Given this list of marker genes Tln1, Ndufb8, Rrp1 (NCBI Gene Id 18114), Tecr, Rgs3, Tmed10, Scgb1a1, Tmem160, Cdkn2c, Mt1, S100a8, Calm1 (calmodulin 1), Hspb1, Sf3b2, Gstp1, Tmt1a, Psme1, B2m, Ftl1, Trappc1, Ybx1, Cd63, Npdc1, Phlda3, Selenbp1 (selenium binding protein 1), Tmem50a, Dnajc3, Hsp90aa1, Ubb, Serping1, Eif3f, Pla2g12a, Cyc1, Psma6, Cfb, H2-K1, Selenos, Ddah2, Rasgrp2, Spint2, Park7, Ndufa12, Ly6e, Etfb, Mdh1, H2-Q4, Manf, Mtdh (NCBI Gene Id 67154), Id3, Hsd11b1, Prss30, Prkca (NCBI Gene Id 18750), Rabac1, Psma3, Pebp1, Pdlim2, Hadh, Ctsz, Dpm1, Rbfa, S100a9, Gpx4 (NCBI Gene Id 625249), Cd74, Psmb10, Eif4ebp1, Aebp1, Rarres2, Myl12a, Tmsb4x (thymosin, beta 4, X chromosome, NCBI Gene Id 19241), Gadd45b, Tmed3, Srp14, Nap1l1, C3, Srrm2, Apoe, Fth1, Pnrc1, Ramp2, H2-Ab1, Des, Slc25a3, Nfkbia, Ndufs2, Gsta3, Tnfaip2, Mfap4, Rassf1, Bsg, Atf3, H3f3b, Gstm2, Cdk2ap2, Ubxn4, Mgll, Psmc2, Ddt, H2-D1, Nr4a1, Stub1, Stbd1, Tmem204, Grina, Cyba, Snhg11, Arhgdia, Ilk, Hoxa5, Cd302, Hes1, Cebpd, Emd, G0s2, Tbcb, Snrpb, Ddrgk1, Atf4, Anxa1, Gstm1, Tyrobp, Fermt2, Hint1, Etfa, Fmo2, Cdkn1a, Adm, Slc7a10, Mat2a, Mrpl58, Sdhc, 2210016L21Rik, Mgst1, Ly6c1, Tmem176a, Gm4956, Akr1a1, Hsp90ab1, H1f2, Plpp3, Rras, Ldhb, Car2, Slc25a5, Tsen34, Cdo1, Gpx3, Vdac3, H2-Eb1, Rrs1, Tmem176b, Lyz2 (NCBI Gene Id 17107), Hilpda, Rhoc, Acaa1a, Swi5, Scp2, Cryab, Ypel3 (yippee like 3), Ifrd1, Saraf, Cfl1, Dctn3, Serpinb6a, Cd40, Aldoa, Ctsl, Prdx5, Psmb8, Sbds, Ly6a, Atp6v0b, Drap1, Dnajc1, Prr13, Prdx6, Kcne4, Zfp36l1, Cirbp, Srsf5, Selenom (NCBI Gene Id 216508), 4930523C07Rik, Klf9, Spr, Lxn, Naxd, Hebp1, Cox4i1, Lgals3bp, Inmt (indolethylamine N-methyltransferase), Filip1, Trf, Tubb4b, Dnajb2, Aldh2, Slc3a2, Son, Fabp3, Laptm4a, Map1lc3a, Kif5b, Rbms1, Vps28, Sh3glb1, Epas1, Tsc22d1, Ubc, Mtarc2, Ppp1r14a, Syf2, H2bc4, Bst2, here is a description of the gene set: species: Mus musculus from publication Tabula Muris Consortium (PMID 32669714) Mouse Gene Set: TABULA_MURIS_SENIS_LUNG_FIBROBLAST_OF_LUNG_AGEING